The following is a description of a gene set: Genes up-regulated in comparison of CD4 thymocytes versus naive CD4 T cells from cord blood. from publication Lee MS, Hanspers K, Barker CS, Korn AP, McCune JM (PMID 15210650) Human Gene Set: GSE1460_CD4_THYMOCYTE_VS_NAIVE_CD4_TCELL_CORD_BLOOD_UP Subpopulations of human fetal thymocyte and circulating naïve T cells were obtained through FACS sorting, including CD3-CD4+CD8- intrathymic T progenitor cells (ITTP), CD3intCD4+CD8+ \double positive\ thymocytes (DP), CD3highCD4+CD8- \single positive\ thymocytes (SP4), CD3+CD4+CD8-CD45RA+CD62L+ naive T cells from cord blood (CB4+), and CD3+CD4+CD8-CD45RA+CD62L+ naive T cells from adult blood (AB4+). studied in species Homo sapiens, and this is the list of marker genes: CDV3, CD1B, GABPA, TP53BP2, GLT8D1, ABCB1, RAD54B, MARCKS, RSAD2, HSPA5, TMEM50A, PIK3R4, TSN, MAP2K6, INTS7, APMAP, TNFRSF1B, IARS2, PSMC2, SPINK2, RAB8B, PTCH1, AATF, TFRC, TNF, SRSF3, ETF1, PSMD7 (proteasome 26S subunit, non-ATPase 7), THUMPD1, HNRNPA1, ELK3, SMYD3, GPR65, NREP, DNTTIP2, RAP1GDS1, SLC39A7, HNRNPD, SEPTIN7, CBX3, MYB (MYB proto-oncogene, transcription factor), SRF, HMGB1, PCCB, PGRMC1, FAM136A, ELOC, STAU2 (staufen double-stranded RNA binding protein 2), ERMP1, POLB, IMMT, ALG8, MR1, TARDBP, DLD, RNF34, MLLT11, ITCH, CPA3, DUSP6, HNRNPA0, CORO1C (coronin 1C), VDAC1, NIT1 (NCBI Gene Id 4817), UBE2E3, DHRS3, PIK3R3, FBXO11, CD44, GOT1, CUL1, LIMK2, HNRNPH1, YWHAQ, SC5D, UBE3A, CALU, POLR2A (RNA polymerase II subunit A), CRNKL1, VPS26C, PSMD6, PDE4D, DNAJB2, BTBD1, TMEM248, LCP1, TMSB15B, PUM3, YPEL1, SLC22A18AS, DYNC1I2, ZMPSTE24, PRKRIP1, LAP3, C2CD2L, PDGFA, ZNF12 (zinc finger protein 12), RAC2, FOXI1, RPS23, COPB2, AAGAB, TM9SF3, TPM4, RNF4, TRIM38, SF3B1, AHI1, LRRFIP2, GNA15, RPP30, OSBPL8, HGSNAT, POMP, NUP107, DCLRE1A, VIM, DENR, DDX1, TCF7L1, PTP4A2, WDR1 (WD repeat domain 1), HEXA, ENC1 (ectodermal-neural cortex 1), NFATC1, MAPK14, TRAPPC2, TDP1, EEF1A1, TIMM17A, GTF3C3, NCBP1, UCHL5, STMN1, ZNF263, HDAC4, ADAR, CMTM6, CHD9, CEP170, TRIB1, MCFD2, SUMO3, CD200, C10orf88, RIMS3, SSR1, ALG9, NEMP1, TTC33, UQCRC2, TPT1, NME7, FHL2, PTTG1IP, NMU, SMURF1, NAB1, MDH1, RPL9 (NCBI Gene Id 6133), MSH2, SLC25A13, ITM2A, HSP90AA1, NPC1, LANCL1 (LanC like glutathione S-transferase 1), CNOT6, FIG4, ERCC8, TPD52L2, RIOK2, BARD1, TOR1A, RTCA, RBM12, SLC25A3, XRCC2, EPAS1, EXOG (NCBI Gene Id 9941), SCFD1, LIG4, TOR1B, GSTA4, RFC1, ZNF148, GLMN, USP39, SPTLC2, KLF10, PPP4R1, GORASP2, SRPRB, CAPRIN1, ADH5, CLK2, ATG3, ST3GAL5, XRCC3, G3BP2, ACTG1